Given this list of marker genes CD247, ANAPC16, SYBU, TRPC6, NFAT5, NFS1, CADM2, KLHDC8A, RAB3B, FYTTD1, LSAMP, KPNA4, GCNT4, SLC1A4, OSBPL7, SMAD5, GALNT7, DVL3, SPX, ADAMTS15, DGKI, MAP4K4, BFAR, HOXA5, IFFO2, NALF2, RAB3C, GIPC3, ZNF503, MIXL1, SERTAD2, RNF44, GFRA2 (NCBI Gene Id 727724), NETO1, ARHGEF7, SH3PXD2B, here is a description of the gene set: studied in species Homo sapiens Genes predicted to be targets of miRBase v22 microRNA hsa-miR-6874-5p in miRDB v6.0 with MirTarget v4 prediction scores > 80 (high confidence targets). Human Gene Set: MIR6874_5P from publication Chen Y, Wang X (PMID 31504780)